Given this list of marker genes Pah, Tat, Fah, Il4i1, Gstz1, Hgd, Qdpr, Hpd, here is a description of the gene set: Mouse Gene Set: GOBP_L_PHENYLALANINE_CATABOLIC_PROCESS studied in species Mus musculus The chemical reactions and pathways resulting in the breakdown of phenylalanine, 2-amino-3-phenylpropanoic acid.